The following is a description of a gene set: The movement of a monocyte in response to an external stimulus. Mouse Gene Set: GOBP_MONOCYTE_CHEMOTAXIS studied in species Mus musculus, and this is the list of marker genes: Fpr2, Pdgfb, Ano6, Slamf8, Rps19, Hmgb1, Ccr2, Slit2, Fpr-rs7, Myo9b, Tnfsf18, Fpr-rs3, Serpine1 (serine (or cysteine) peptidase inhibitor, clade E, member 1), Lgals3, Ccl12 (NCBI Gene Id 20293), Cx3cr1, Pla2g7, Ccl5, Fpr-rs6, Ccl2, Anxa1, Flt1, Cxcl17, Grem1, Ninj1 (NCBI Gene Id 18081), Ccl26, Ccr1, Fpr-rs4, S100a14, Ccr1l1, Lyn, Creb3, Aif1, Nbl1, Dusp1, Ptpro, Lgmn, Cxcl12, Msmp, Ctsg, Ccl3, Defb25, Mospd2, Ccn3, Ccl1, Tnfsf11, App, Cxcl10